The following is a description of a gene set: Cytokine-activated STAT proteins dimerize and bind to high-affinity motifs, and N-terminal domain-mediated oligomerization of dimers allows tetramer formation and binding to low-affinity tandem motifs, but the functions of dimers versus tetramers are unknown. We generated Stat5a and Stat5b double knock-in (DKI) N-domain mutant mice that form dimers but not tetramers, identified cytokine-regulated genes whose expression required STAT5 tetramers, and defined consensus motifs for dimers versus tetramers. Whereas Stat5- deficient mice exhibited perinatal lethality, DKI mice were viable, indicating that STAT5 dimers were sufficient for survival. Nevertheless, STAT5 DKI mice had fewer CD4+CD25+ T cells, NK cells, and CD8+ T cells, with impaired cytokine-induced proliferation and homeostatic proliferation of CD8+ T cells. DKI CD8+ T cell proliferation following viral infection was diminished and DKI Treg cells did not efficiently control colitis. Thus, tetramerization of STAT5 is dispensable for survival but is critical for cytokine responses and normal immune function. Human Gene Set: GSE36888_UNTREATED_VS_IL2_TREATED_TCELL_17H_UP Genes up-regulated in T cells: control versus IL2 stimulation for 17h. from publication Lin JX, Li P, Liu D, Jin HT, He J, Ata Ur Rasheed M, Rochman Y, Wang L, Cui K, Liu C, Kelsall BL, Ahmed R, Leonard WJ (PMID 22520852) species: Homo sapiens, and this is the list of marker genes: ZYG11B, KIF22, ZBED3, WDR7, NARS1, PTGR3, GAS2L3, CAMK1, MDFIC (NCBI Gene Id 29969), ADA2, SDS, CLEC2B, RNASET2, SCARB2, MPND, GPX3, A2M, NME8, CZIB, KCNJ5-AS1, MAP4K3, NUDT19, CASP10 (NCBI Gene Id 843), EPHB2, IFTAP, TUT7, TXNIP, MEF2C, CPVL, MS4A6A, ADCK1 (NCBI Gene Id 57367), ABHD14A, DHRS9, SLC7A8, HGF, EPS8, ACTMAP, STARD13, WDR91, CAT, S100Z, FABP4, BLVRB, TMEM134, TREML1, AKR1A1, TLR7, FNTB, DIRC3, TNFSF13B, NANP (NCBI Gene Id 200269), GGTA1, GCLC, REV3L, ECHDC1, ZFP64, FECH, IQGAP2, GRN, AMZ2P1, NDUFB5, LGALS9, ARMCX1, CD2AP, RASA1, CD9 (CD9 molecule), HHEX, CFD, CCNY, SETD7, SPTLC3, RAB7B, TBC1D9B, GPNMB, TESK1, ASRGL1, ATP5F1A, LY86, CHN2, RASAL2, PLA2G15, SKIC3, PCNA, CIITA, TM7SF3 (transmembrane 7 superfamily member 3), LTC4S, CHST13, CMTM7, ACRBP, TAF9, RPS6KA2, FAM13B, CD302, CADM1, HLA-DMB (major histocompatibility complex, class II, DM beta), TMEM144, BACE1, CD52, PPT1, TECR, PRCP, HDHD2, SLC16A5, PON2, ALDH3A2, COQ8A, OSBPL1A, CNRIP1, PALLD, OAS1, REPS2, FRMD4B, PREPL, MRM2, TIMP2, APOC1, SEPTIN2, AVPI1, FAM13A, PMFBP1, MPP1, HPS3, GRSF1, PLCB1 (NCBI Gene Id 23236), DBP, SELENOP, PLD3 (NCBI Gene Id 23646), HAVCR2, GPR82, CRHBP, GDPD1, CRTAP, RHOBTB1 (NCBI Gene Id 9886), CBR4, MAML3, MEF2A, ATP6AP2, RAPH1, OXA1L, LGMN (legumain), CD86, TNS1, MRO, FAM78A, GALM, ADGRD1, HADH, DDX19A, POLE3, MBNL3, SORBS3, CLEC3B, SNX29, ITGB5, FABP5, CST6, CEBPA, OSBPL3 (oxysterol binding protein like 3), CDKN2AIP, PABPC4, TREM2 (triggering receptor expressed on myeloid cells 2), TPCN1, ANGPT1, ME1, DEPTOR, CD101, RFX7, TNFRSF11A (NCBI Gene Id 8792), ATP2B1, C5, HLA-DMA, CD1E, HLA-DRA, FAM135A, MIF4GD, PFKFB2, ABHD10, SHMT1, GUSB, SPTSSA, NDUFA4, DPEP2, LGALS3, RNF135, VPS13C (NCBI Gene Id 57581), ADK, STMN1, RAB42, PRPS2, VAPA, ATP1B1 (NCBI Gene Id 481), HEXA (NCBI Gene Id 3073), CHEK2, ACADM (acyl-CoA dehydrogenase medium chain), CBR1, CD180, SRD5A3, PFDN5, GPR34